The following is a description of a gene set: Any process that activates or increases the frequency, rate or extent of signal transduction mediated by the ERK1 and ERK2 cascade. Human Gene Set: GOBP_POSITIVE_REGULATION_OF_ERK1_AND_ERK2_CASCADE studied in species Homo sapiens, and this is the list of marker genes: TNF, FFAR4 (free fatty acid receptor 4), CCL19, GCNT2 (NCBI Gene Id 880), FPR2, MAP2K1, NOTCH2, CSF1R, GAREM1, GNAI2, HLA-DRB1, MIR27B, FSHR, CHRNA7, MIR519D, TPBG, ADCYAP1, MAPK3, TIRAP, PDGFRA, BMP4, IL1B, HMGB1, PDE8B (phosphodiesterase 8B), RAP1B, OR2AT4, ICAM1 (NCBI Gene Id 3383), FGF18, BRAF, PTK2B, PLA2G2A, NPY, CCL21, SEMA7A, FGFR2, TNFRSF11A, PDGFC, C5AR1, ALKAL1 (NCBI Gene Id 389658), BMP2, PRKD2, MT3, FGF23, PTPRC, FGB, MIR24-1, TNFAIP8L3, NPY5R, CFLAR, HRAS, CHI3L1, FGFR3, CALCR, ABL1, SHC1, FGG, ADORA2A, FLT4, NODAL, ADRA1A, PDGFRB, MTURN, TEK, NECAB2, MIF, FGA, THPO, DRD2, NRXN1, SLAMF1, IGF1, SRC, PDE8A, NOD1, S100A7 (NCBI Gene Id 6278), AGER, TRPV4, ALKAL2 (NCBI Gene Id 285016, ALK and LTK ligand 2), PYCARD, PDGFA, GPBAR1, VEGFA, SYT14P1, NTRK1, NRP1, GLIPR2 (NCBI Gene Id 64148), NOX4, DUSP15, HAND2, PTPN11, MIR126, HTR2B, CD44, JUN, P2RY1, MIR27A, ALOX15, FGF4 (fibroblast growth factor 4), PDGFB, TNFSF11, ACKR3, CCL3, NOD2, IL26, IAPP, DSTYK, FERMT2, CARD9, ITGB3 (integrin subunit beta 3), FGFR4, RAMP3, PTPN22, SLC30A10, BMPER, PRKCZ, PRXL2C, ACTA2, GPR183, GAS6, GPNMB, P2RY6, GPR55, MOS, CXCL17, PLA2G5 (NCBI Gene Id 5322), NPNT, APOE, HTR2C, NELFE, CCR1, GCG, NAMPT, TLR4, ERBB4, F2R, GPER1, PHB1, NGF, AKAP12, EGFR, F2RL1, RIPK2, CD4, APP, OPRM1, PDGFD, DNAJC27, DENND2B, CIB1, CCN2, TGFB1, ANGPT1, SPRY2, ARRB1, MARCO, PRKCA, CAVIN3, INHBA, CASR, HTR2A, SERPINF2, SCIMP, CCR7, VEGFB, FGF8, MIRLET7B, MAP3K12, NRG1, EPO, MIR21, CD36, HCRTR1, FGF1, NPSR1, MFHAS1, FBXW7, NDRG4 (NCBI Gene Id 65009), CD74, FGF19, ARHGAP8, NOTCH1, FGF2, MAP2K7, ARRB2, RAPGEF2, LGALS9, FGF20, RAP1A, TREM2, HAVCR2, ABCA7, KDR, DDR2, FGF21, MIR23A, PHB2, DDT, CX3CL1, FGF10, APELA, CRKL